The following is a description of a gene set: Genes upregulated in subsets of cells of a given type within various tumors studied in species Homo sapiens from publication Gavish A, Tyler M, Greenwald AC, Hoefflin R, Simkin D, Tschernichovsky R, Galili Darnell N, Somech E, Barbolin C, Antman T, Kovarsky D, Barrett T, Gonzalez Castro LN, Halder D, Chanoch-Myers R, Laffy J, Mints M, Wider A, Tal R, Spitzer A, Hara T, Raitses-Gurevich M, Stossel C, Golan T, Tirosh A, Suvà ML, Puram SV, Tirosh I (PMID 37258682) In this study, an extensive analysis was conducted to define meta-programs (MPs) capturing intra-tumor heterogeneity across a spectrum of tumor types. The approach utilized non-negative matrix factorization (NMF) to analyze each cell type separately within individual tumor samples. This involved the analysis of malignant cells, macrophages, fibroblasts, endothelial cells, epithelial cells, T-cells, and B-cells. NMF was executed with varying parameter values (K=4, 5, 6, 7, 8, 9), thereby generating 39 programs for each cell type per sample. Each NMF program was summarized by the top genes based on NMF coefficients.\nRobust MPs were then delineated for each cell type using a set of stringent criteria, including recurrence within the same tumor, similarity to programs in other tumors, and non-redundancy within a tumor. Subsequently, these robust NMF programs were clustered (per cell type) based on Jaccard similarity, leading to the identification of MPs associated with each cell type.\nTo enhance the quality of the MPs, a refinement steps were undertaken, involving the removal of MPs suspected of reflecting low-quality data (with an overrepresentation of ribosomal proteins or mitochondrial-encoded genes), single-study inclusion, or similarity to miss-annotated cell types. Human Gene Set: GAVISH_3CA_MALIGNANT_METAPROGRAM_13_EMT_2, and this is the list of marker genes: FSTL3, INHBA, LGALS1, TNC, IL32, S100A2, TGFBI, MT2A, SERPINE1, ITGA3, FN1, F3, PLAUR, DCBLD2, CAV1 (caveolin 1), LAMC2, ITGAV, LAMA3, EMP3, THBS1, CAVIN3, IGFBP6, MMP7, KRT7, C15orf48, FLNA, COL17A1, TPM1, IGFBP7, ITGB6, PMEPA1, ANXA3, ITGB1, TNFRSF12A, ITGA6, TGM2, RHOD, KRT17, CDA, LAMB3, CST6, RBP1, PDLIM7, SERPINE2, VIM, CDKN1A, PLAU, PRSS23, PTHLH, PDPN